The following is a description of a gene set: Human Gene Set: NFY_Q6_01 species: Homo sapiens Genes having at least one occurrence of the motif NNNNRRCCAATSR in the regions spanning 4 kb centered on their transcription starting sites. This matches the transcription factor binding site V$NFY_Q6_01 (v7.4 TRANSFAC)., and this is the list of marker genes: POU3F3, KPNA4, ZNF8, PRR11, ANAPC5, ELAVL4, DOLPP1, MTFP1, TSNAXIP1, PPP2R5A, PPP2R5C, PNRC2, ZCCHC12, ASIC2, SLC43A2, AGAP3, MAEA, TOMM40, RFX5, CDV3, RNF5, SYNGR4, TMEM143, LY75, UBXN11, FDXR, CNTD1, DHCR24, BCAT2 (branched chain amino acid transaminase 2), PPM1A, SPRY2, ANKRD12 (NCBI Gene Id 55606), BCKDHA, TBX2, SLIT3, H3C1, SKA2 (NCBI Gene Id 348235), KIF20A, SNRPA, GRHL3, MAPK7, H2AC6, SREBF2, KLHL4, STMN1, SH3GL3, C1orf105, NKX6-1, RBBP4, ZNF711, TENM3-AS1, HSPA1A, AGFG2, PNN, TTC9C, RPS6KL1, RPRD2, MLYCD, FAM204A, HOXB9, H2BC1, UGP2, CDH1, ACR, PIK3R3, ATOH1, HSCB (HscB mitochondrial iron-sulfur cluster cochaperone), PLA2G3, MOB1A, NUAK2, MYO1E (NCBI Gene Id 4643), GLB1L2, PDP1, GJB4, TAFA4, TCTA, DAXX, BAHD1, FADS1, TP53BP1, CNN3, ZBTB10 (zinc finger and BTB domain containing 10), PCF11, GNAI2, RANBP10, PPP1R1B (NCBI Gene Id 84152), SPRED2, ZNF362, INVS, HIGD1A, CDC25A, GCA, SLC25A13, SUN2, MRTFA, RLN1, CADM2, ACTMAP (NCBI Gene Id 284325), SFRP1, GJB5, RPA2, HOXC4, H2AC1, ZBTB20 (zinc finger and BTB domain containing 20), HNRNPR, PASK, ZFP91, TGFB3, PPP4R4, ZNF189 (zinc finger protein 189), LDB2, HIF1A, SEL1L, HIVEP3, ASPHD1, EIF2AK3, KLF9, EEF1DP3, UBALD2, EPC2, STARD13, SLC2A1, GRHL2, LRATD1, MYOCD, SCD, TUG1, NOL4, JARID2, STMN2, SIX2, DHTKD1, XPO1, NR2C2, SYCP3, GNGT2, SERPINA6, SIK3, NRDC, MRPL50, COA3 (NCBI Gene Id 28958), ZNF436, ACTL6A, CATSPER2, FAM117A, MLEC, TXNIP, MTMR4, DDX50, SF1, PDGFRB, KDM3A, ZDHHC5, AP2A1, RAB5IF, DCUN1D4, IFT27, NUBP2, H3C3, MTMR14, RHOA, H2AC12, PLK1, CDC14B, GART, NKX6-2, GGNBP2, AGPAT1, PRKACA, CCDC51, ATF6B, NT5DC2, H2BC4, PDIA3, MICAL2, GPR50, STIMATE (NCBI Gene Id 375346), CREBRF, UVRAG, H2BC12, FAM76B, WNT3, ZBTB8OS, GTF2A1L, ELAC2, CIT, SESN2, MAEL, PRUNE2, RTN2, PIAS4, BORA, PRDM10, CALM2, DLG2 (NCBI Gene Id 283225), KBTBD8, PIK3R1, HLA-DOA, HMGN3, TYSND1, KCNJ13, LRP8, CELSR3, SHC3, PTCH2, BRD8 (NCBI Gene Id 10902), MCM8, ZNF436-AS1, GGCT, PDK2, COMMD10, NDE1, GREM1, E2F8, RBM3, NEK2, PAN2, CHAC1, OS9, DOCK9, VCP, CTF1, EDA, SMAD2, HELB, ETV5, ELMO1, ABCF2 (ATP binding cassette subfamily F member 2), TMA7, ZBTB5, ABI3, LPCAT3, DLG3, CEP57, RACGAP1, GPCPD1, SLC2A4, DGKZ, PPP1R7, HSPA1B, FDFT1, TRMT6, NUP93, HDAC1, PIM3, HMGN2, ZNF385A, SHH, DSPP, EMX2, ATP2A2, COL1A1, H4C1, USP21, HSPA1L, FOSB, SON, TP63, HERPUD1, ARL17A, DPYSL5, KCNN2, WNT8B, KATNB1, SIGMAR1